The following is a description of a gene set: The region of the myelin sheath nearest to the axon. species: Mus musculus Mouse Gene Set: GOCC_MYELIN_SHEATH_ADAXONAL_REGION, and this is the list of marker genes: Pals1, Mag, Pten, Anxa2, Cnp, Stx4a